The following is a description of a gene set: species: Homo sapiens Human Gene Set: REACTOME_NEGATIVE_FEEDBACK_REGULATION_OF_MAPK_PATHWAY Negative feedback regulation of MAPK pathway, and this is the list of marker genes: MAP2K2, MAPK1, MAPK3, MAP2K1, RAF1, BRAF